The following is a description of a gene set: The regulated release of milk from the mammary glands and the period of time that a mother lactates to feed her young. Mouse Gene Set: GOBP_LACTATION studied in species Mus musculus, and this is the list of marker genes: Atp2b2, Stat5a, Slc6a3, Aprt, Prl7d1, Prl3b1, Prlr, Rplp0, Cav1, Prl, Prl3a1 (prolactin family 3, subfamily a, member 1), Prl8a1, Hif1a, Prl8a6, Prl4a1, Prl7b1, Nme1, Abcb1a, Ccnd1, Prl3d2, Prl3c1, Uprt, Kalrn, Prl8a2, Erbb4, Umps, Prl7a2, Prl2c3, Prl8a8, Xdh, Neurl1a, Csn3, Vdr, Cdo1, Ddr1, Prl2b1, Atp7b, Ghrhr, Gja1, Creb1, Foxb1, Prl2c2, Slc29a1, Cad, Prl2c1, Vegfa, mt-Co2, Prl7a1, Stat5b, Prl8a9, Prl2a1, Prl2c5, Prl5a1, Usf2, Prl7c1, Gpat4, Csn2, Eif2ak3, Prl6a1, Socs2, Prl3d1, Med1, Chuk, Prl3d3, Oas2, Xbp1, Zbtb7b, Hk2, Ncoa1